The following is a description of a gene set: Human Gene Set: HP_ABNORMAL_GLYCOSPHINGOLIPID_METABOLISM Abnormal glycosphingolipid metabolism species: Homo sapiens An abnormality of glycosphingolipid metabolism., and this is the list of marker genes: MCOLN1, HEXA (NCBI Gene Id 3073), PSAP, GLA, ARSA, HEXB, GM2A